Given this list of marker genes IFT46 (intraflagellar transport 46), IFT88, IFT57, IFT22, IFT52, IFT20, UBXN10, IFT172, IFT80, TRAF3IP1, IFT81, TRIM59, IFT70B, IFT70A, IFT74, CLUAP1, IFT25, IFT27, IFT56, here is a description of the gene set: species: Homo sapiens The larger subcomplex of the intraciliary transport particle; characterized complexes have molecular weights around 550 kDa. Human Gene Set: GOCC_INTRACILIARY_TRANSPORT_PARTICLE_B